The following is a description of a gene set: studied in species Mus musculus Mouse Gene Set: GOBP_INORGANIC_ANION_TRANSPORT The directed movement of inorganic anions into, out of or within a cell, or between cells, by means of some agent such as a transporter or pore. Inorganic anions are atoms or small molecules with a negative charge which do not contain carbon in covalent linkage., and this is the list of marker genes: Slc4a2 (solute carrier family 4 (anion exchanger), member 2), Slc17a8, Clcn7 (chloride channel, voltage-sensitive 7, NCBI Gene Id 28069), Slc5a8, Slc4a9, Slc26a9, P2rx5, Slc20a1, Tmc4, Ttyh2, Slc37a4, Slc26a3, Slc25a27, Slc4a7, Slc37a1, Slc6a14, Mtor (NCBI Gene Id 80612), Slc25a10, Gabrr3, Slc12a2, Slc17a7, Mfsd5, Enpp1, Ano10, Gabrb2 (gamma-aminobutyric acid type A receptor subunit beta 2), Gabrb3, Slc12a9, Ano4, Slc12a4, Prkg2, Atf4 (activating transcription factor 4), Ano1, Clcnkb (NCBI Gene Id 56365), Tspo, Clca2, Slc12a1, Clic4, Slc22a8, Pacc1, Slc11a1, Nmur1, Mfsd8, Gabrg3 (gamma-aminobutyric acid type A receptor, subunit gamma 3), Pcyox1, Slc25a30, Fxyd1, Gabrq, Slc25a14, Sfrp4, Clcn1, Slc4a8, Cry2, Gabra2 (NCBI Gene Id 78710), Bsnd, Slc5a6, Gabrb1, Slc6a2, Apol11a, Car7 (carbonic anhydrase 7), Slc20a2, P2ry4, Ano6, Ano9, Slc26a8, Slc12a8, Fgfr1, Kcne2, Clic3, Gabrr2, P2ry6, Best2 (NCBI Gene Id 212989), Ano5, Ucp2, Ano8, Clcc1, Slc17a4, Gabra1, Clcn2, Slc26a5, Slc4a1, Ttyh1, Slc34a3, Best3, Cldn4, Wnk4, Clic6, Clcn4, Racgap1, Clca4a, Gabrg2, Slc26a6, Slc17a1, Slc12a6, Glra1, Lrrc8a, Slc5a5, Clic5, Ttyh3, Slc26a11, Aqp6, Clcnka, Ano7, Slc1a4, Slc4a5, Tg, Gabra4, Cebpb, Clcn3, Slc12a7, Gabrr1, Slc4a3, Clca3a1, Slc4a11, Xpr1, Clns1a, Clca1, Kcnq1, Stc2, Gabra6, Cldn17, Slc22a6, Casr, Slc12a3, Ank, Slc26a10, Glra4 (NCBI Gene Id 237054), Oca2, Slc26a2, Slc12a5, Abcb1b, Slc17a6, Best1, Clca3a2, Clcn5, Cftr, Clic1, Kcnk2, Slc6a1, Abcb1a, Slc26a4, Glrb, Atp8b1, Ano3 (NCBI Gene Id 99077), Kcnk1, Vdr, Glra2, Gabrg1, Slc4a4, Car2, Slc13a1, Slc1a7, Nmur2, Abcc6 (NCBI Gene Id 54597), Ano2 (NCBI Gene Id 243634), Glra3, Slc37a2, Fgf23, Slc4a10, Slc34a1, Ip6k2, Slc26a1, Slc26a7, Clcn6 (NCBI Gene Id 26372), Gabrp (gamma-aminobutyric acid type A receptor subunit pi), Slc1a3, Fgfr4, Gabra3, Gabrd, Ostm1, Gabre, Slc25a3, Chrm5, Slc1a1, Slc34a2, Ros1, Gabra5